Given this list of marker genes SCARF1, MIR221, GRN, PUM2, CNTF, PTN, BRAF, MIR222, MIR431, NTRK3, here is a description of the gene set: Human Gene Set: GOBP_POSITIVE_REGULATION_OF_NEURON_PROJECTION_REGENERATION species: Homo sapiens Any process that activates or increases the frequency, rate or extent of neuron projection regeneration, the regrowth of neuronal processes such as axons or dendrites following their loss or damage.